Given this list of marker genes Amd1, Sat1, Agmat, Oaz1, Ldc1, Oaz2, Azin1, Oaz3, Azin2, Odc1, Srm, Paox, Sat2, Sms, Amd2, here is a description of the gene set: studied in species Mus musculus Mouse Gene Set: GOBP_POLYAMINE_BIOSYNTHETIC_PROCESS The chemical reactions and pathways resulting in the formation of polyamines, any organic compound containing two or more amino groups.